The following is a description of a gene set: A process that results in the assembly, arrangement of constituent parts, or disassembly of a postsynaptic density, a region that lies adjacent to the cytoplasmic face of the postsynaptic membrane at excitatory synapse. studied in species Mus musculus Mouse Gene Set: GOBP_POSTSYNAPTIC_DENSITY_ORGANIZATION, and this is the list of marker genes: Zmynd8, Fgfr1, Sipa1l1, Abi3, Dlg2, Reln, Nrxn3, Dgkz, Cfl1, Adgrl3, Shank1, Lats1, Abi3bp, Prickle2, Arf6, Caskin1, Nlgn2, Pten, Nptx1, Dbn1, Il1rap, Nrxn2, Ptk2b, Hspa8, Nlgn1, Cit, Cadm1, Slitrk3, Slc30a1, Lrfn4, Lrrc4b, Itgb3 (NCBI Gene Id 268495), Nrxn1, Ptprs, Cntnap2, Cript, Lrrc4, Lrrtm1, C1ql2, Shank3, Ophn1, Csmd2, Ptprd, Prickle1, Grid2, Ntrk3, Mpp2, Lrfn1, Itgb1, Cbln1, Lrrtm2, Zdhhc12, Cntnap1, C1ql3, Cdh2, Syngap1, Rapsn, Tmem108, Dlg1